The following is a description of a gene set: Human Gene Set: HP_ABNORMALITY_OF_THE_PANCREAS An abnormality of the pancreas. Abnormality of the pancreas species: Homo sapiens, and this is the list of marker genes: ZMYM3, BMPR1A, NHP2, IFT172, CHEK2, CDKN1B, RABL3, ASL, SBDS, NSMCE2, GCGR, ENPP1, NEK1, TLR4, TMEM237, CFTR, MT-ND1, RBM8A, MYCN, TF, STX1A, PKHD1, TYMS, PDPN, BRIP1, NEUROD1, SLC26A9, MT-CO2, BCKDHA, BSCL2, CDKN1C, WDR19, GNAS, MMP23B, ABCC6, TGFBR2, RPGRIP1, MT-CO1, KCNAB2, RAD50, PARN, GLUD1, POT1, IVD, ALG9, HLA-B, NTHL1, SETBP1, NDUFS3, CTC1, NR1H4, IL12A-AS1, BRD4, MT-ND5, POLE, NPM1, RNU7-1, TMEM107, TRMT5, BICC1, XPNPEP3, LHX1, CTNS, BLK, C4A, IGF2, PRKCSH, CIDEC, GANAB, MT-TL1, WNT7B, UBR1, IFT140, VHL, BRCA2, INSR, HNF4A, JAG1, CAV1, SRP54, SPINK1, ATP6AP1, PDX1, PRKAR1A, PKD2, ATP7B, TXNDC15, PNPLA2, TMEM216, PPARG, BRCA1, SMARCAL1, PRIM1, HMOX1, KCNN4, PCCB, CBS, USB1 (NCBI Gene Id 79650), GNA11, CDKN2B, FLNB, PTEN, POLD1, RAD51C, PRKCZ, PKD1, CSPP1 (centrosome and spindle pole associated protein 1), UBAC2, SEC63, TERF2IP, IL10, UQCRH, CTRC, FAH, MT-TH, NFS1, APPL1, SLC9A3 (solute carrier family 9 member A3), PRTN3, ASXL1, ABCB11, GATA6, STRA6, ACVR1B, RFX6 (NCBI Gene Id 222546), HFE, RTEL1, GCK, STK11, NPHP3, TINF2, MLH1, HNF1B, CEP290, KLRC4, ARX, MPV17, PTF1A, TCTN1, B9D2, TCF4, ABCB4, SKIC3, GCLC, ACD, PUF60, MIF, NSD2, DIS3L2, DKC1, ALG5, FANCD2, SLC6A14, AGPAT2, YARS1, TKFC, RECQL4, TMEM231, HLA-DPA1, LMF1, MKS1, EFL1, APOC2, TERT, MT-ND6, MEN1, ALMS1, SLC7A7, LUZP1, WT1, HOXD13, DZIP1L, AAGAB, MEFV, CDKN2A, EPCAM, IFNGR1, GPC3, PAX4, CLCA4, MT-CO3, UBE4B, MADD, IL12A (interleukin 12A), SLC11A1, NUTM1, RPGRIP1L, CDKN1A, IKZF1, FOCAD, MSH2, HLA-DPB1, EWSR1 (NCBI Gene Id 2130), G6PC1, FCGR2A, PTRH2, MAFA, MITF, OFD1, AP2S1, NADK2, WRAP53, CLCNKB, MST1, MUTYH, PTPN22, CDK4, TERC, MSH6, RERE, PMS2, ACTG2, APOE, SLC16A1, SEMA4A, UCP2, FAS, MT-TS2, CPA1, MC1R, ESAM, CCDC47, HAMP, MT-TQ, STUB1, PDGFRB, MMUT, LBR, PIK3CA, LRP5, CEL, SCNN1A (NCBI Gene Id 6337), FGFR2, GPR35, CP, ABCC8, CASZ1, GLIS3, SLC29A3, GPIHBP1, SKI, APC, PRSS2, TGFB1, SLC25A13, MGMT, LPL, HMGCL, PDE11A, MT-TW, PALB2, BARD1, CCND1, KCNQ1, RPS20, SERPINA1, CASR, SLC12A3, EIF2AK3, CYBC1, CDC73, GABRD, MDM2, SLC37A4, RAD51, GK, PMS1, COL14A1, LMNA, IL23R, COX4I2, ERAP1, CEACAM3, EDNRA, FLI1, CNOT1, CCR1, TELO2, PRDM16, RAD51D, YY1, KCNQ1OT1, RNF43, HJV, MT-ND4, TRPV6, RARB, CC2D2A (coiled-coil and C2 domain containing 2A), PRSS1, PCCA, AIRE, BAP1, DYNC2I1, RMRP, DNAJC21, SMAD4, TMEM67, KLF11, STAT3, CDKN2C, MT-TF, SIK3, DNAJB11, CEACAM6, NOTCH3, KCNJ11, TCTN3, SCNN1B, STAT4, INS, CTLA4 (NCBI Gene Id 3411), TCTN2, MYC, SEMA4D, GPC4, MRE11, GSTM3, B9D1 (B9 domain containing 1, NCBI Gene Id 27077), FOXF1, NOP10, KRAS, SPEN, ATM, CRELD1, HSPG2, ATP8B1, PALLD, NBN, HNF1A, DCTN4 (NCBI Gene Id 51164), TP53